Given this list of marker genes GNAT2, PDE6H, CNGA3, ATF6, CNGB3, RPGR, PDE6C (NCBI Gene Id 5146), here is a description of the gene set: No detectable response to the light-adapted 3.0 ERG (single-flash cone response). This type of ERG measures responses of the cone system; a-waves arise from cone photoreceptors and cone off-bipolar cells; the b-wave comes from On- and Off-cone bipolar cells. Human Gene Set: HP_UNDETECTABLE_LIGHT_ADAPTED_ELECTRORETINOGRAM studied in species Homo sapiens Undetectable light-adapted electroretinogram